Given this list of marker genes SOX6, TGFB2, MYF5, MYCN (NCBI Gene Id 53360), CCN2, UNCX, PKD1, COL11A1, WNT7A, BMPR1B, MGP, FGF4, THRA, FGF6 (fibroblast growth factor 6), BARX2, BMP1, SOX9, SOX5, COL2A1, MAPK14, OTOR, here is a description of the gene set: studied in species Homo sapiens Human Gene Set: GOBP_CARTILAGE_CONDENSATION The condensation of mesenchymal cells that have been committed to differentiate into chondrocytes.